The following is a description of a gene set: Genes down-regulated in HEK-293 cells (fibroblast) upon knockdown of CTBP1 but not of SATB1 by RNAi. studied in species Homo sapiens Human Gene Set: PURBEY_TARGETS_OF_CTBP1_NOT_SATB1_DN from publication Purbey PK, Singh S, Notani D, Kumar PP, Limaye AS, Galande S (PMID 19103759) Special AT-rich binding protein 1 (SATB1) acts as a global regulator of gene expression by recruiting various corepressor or coactivator complexes, thereby establishing a unique chromatin structure at its genomic targets in a context-dependent manner. Although SATB1 acts predominantly as a repressor via recruitment of histone deacetylase 1 (HDAC1) complexes, the precise mechanism of global repression is not clear. Here we report that SATB1 and C-terminal binding protein 1 (CtBP1) form a repressor complex in vivo. The interaction occurs via the CtBP1 interaction consensus motif PVPLS within the PDZ-like domain of SATB1. The acetylation of SATB1 upon LiCl and ionomycin treatments disrupts its association with CtBP1, resulting in enhanced target gene expression. Chromatin immunoprecipitation analysis indicated that the occupancy of CtBP1 and HDAC1 is gradually decreased and the occupancy of PCAF is elevated at the SATB1 binding sites within the human interleukin-2 and mouse c-Myc promoters. Moreover, gene expression profiling studies using cells in which expression of SATB1 and CtBP1 was silenced indicated commonly targeted genes that may be coordinately repressed by the SATB1-CtBP1 complex. Collectively, these results provide a mechanistic insight into the role of SATB1-CtBP1 interaction in the repression and derepression of SATB1 target genes during Wnt signaling in T cells., and this is the list of marker genes: NID2, ATP5F1B, NEK9, WBP11, SLC39A7, CD69, EXOC2, NDRG4, ZCCHC17, HAPLN4, TCF3, DNAH9, WDR4, DENND11, TULP2, SAYSD1, FETUB, ARHGAP25, JHY, TNFSF13B, GOLGA4-AS1, GOLGA2, SNPH, KLHL2, ITM2B, NDC80, DERA, TRIM55, SH3BP5, COLEC12, HERC2, HNRNPA1P16, IFT88, HRG, IL18RAP, MRPL41, NGEF, SOX2, SPOP, TMLHE, S100A10, PPFIBP2, ADAMTS1, MMP1, BEST2, PRR4, DDX4, FYN, RNF139, SLAMF8, CDKN2AIPNL, PLS1, KRT32, TCAF1, PRPF31, TNFSF8, DOC2B, TUBA3C, CD226, STMN1, PPP1R13L, CYB5B, SAGE1, ACKR4, ADGRV1, TACO1, GTF2E1, TMEM106C, TMEM25, HS3ST3B1, SEC23IP, UBE2D4, ACP5, ACAT2, AKIRIN2, SEPHS1, CDKN2D, WSB1 (NCBI Gene Id 26118), TMEM165, IMPACT, TARBP2, LPCAT1, PPP1R3A, PRPF4, TRH, MPG, FBXO31, FBXO9, DSCC1, PZP, SOAT1, POM121L10P, BBC3, ARL8B, SNX9, PIGHP1, LHX1, CHRM5, SYT12, CALM3, PARP11, SIVA1 (NCBI Gene Id 89639), AP3S1, ETV5, DDX43, KPNA1, SUPT20H, NPC1, JAK3, KBTBD6, KRT71, TBCB, CPA5, HSD17B8, APBB1IP, BET1L, CYP3A4, ANKRD13C, TBX1, POLR2E, ALOX5, TXNDC17, ENPP2, ITGAE, PIK3CB, VRK2, PABPC5, HAPLN1, NENF, CABLES1, POLR3E, BAK1, KLF12, IFITM3, PPP1R2C, DCTN4, PAK2, LMO1, KPNA2, SP4, CEACAM5, GPATCH2L, CIAPIN1, WARS2, PIK3CD, CNTN3, ARID1A, MIR100HG, GDF11, MAP3K7, PPP1R1B, NEB, CCDC186, PDE8B, SESN3, ATXN7, PRR16, RMI1, CLK3, GNG5, GPR143, NRXN3 (NCBI Gene Id 9369), WDR76, VDR (vitamin D receptor), DOP1A, CPVL, KISS1, NUF2, CTTN, PSORS1C2, MAGEA10, CRIP2, DNAI1, VPREB3, SLCO3A1, DSTN, AKAP1, CUEDC2, PTP4A3, CHPT1, TMEM8B, TSPO, PTPN21, PCDH20, VAMP2, NUDT14, IER2, PCDH8, GBP3, MAGEA4, NAA25, ST13, IRX5, NR3C2, MMP17, PMAIP1, RCHY1, PDE8A, FUT6, ABCG2, DDX19B, ADRA2A, PDPN, TMC5, ITM2A, CAPG, NES, RDH10, PPP2R1A, PLCXD1, RAPGEF2, RRM2, RAI2, RNF14, AGR2, SDCBP2, ZNF814, RASD1, CYP7B1, FUT1, FKBP1B, SLC25A36, ASXL2, GHITM (growth hormone inducible transmembrane protein), NCAPH, AREL1, SP110, BNIP3L, THRB, TUBA3D, ENSG00000286190, VBP1, WBP4, TOB2, PMM1, SPANXA2, PLEC, MICU1, GUSB, ROBO4, NAP1L4P1, SLC10A2, MYL6B, TAC3 (tachykinin precursor 3), DDIT4, PTPRF, BID, ABHD4, SRP19, PPP1CC, SLC5A1, KLHL20, AP3B2, MYO15B, TSC22D1, AICDA, GABRA2, DYRK1A, INTS9, DYNC2I1, TNMD, GDF10, BTN3A3 (NCBI Gene Id 135583), LEMD3, WWTR1, ENSG00000258843, PYROXD1, TMEFF1, SMARCD1, PPP3CA, ARHGEF12, GPR161, DDX20, RYR1, HS6ST1, AKNA, PHIP, NAALAD2, MAGEA6, MB, CTDSPL, MT3, DOCK4, TNFRSF25, C18orf32, GTSE1, DKK3, CKMT1A, PRDX1, DLK1, CXCR5, PAX9, TESK2, RORA, TIMM17B, GRM2, LINC00588 (long intergenic non-protein coding RNA 588), FGF5, GHR, CDCA7, SHB, TLE3, SNAPC5 (NCBI Gene Id 10302), ZFAND2B, PRRX1, F8A1, SAT1, KRT4, ZNF26 (zinc finger protein 26), HBS1L, PDE1A, SCN9A, PROS1, HNF1B, PI3, PRPF18, APLN, SERPINH1, MLPH, EPYC, OCA2, BLOC1S2, OGFOD2, MRPS16, HSP90B1, COQ3, RHOXF2B, RBM6, KIF14, ZNF236, KCNC4, OGT, ZNF436-AS1, GTF2H2C, FHIT, RAB5IF, MAPRE3, ZFY, FGA (NCBI Gene Id 2243), EIF5B, CLIP3 (CAP-Gly domain containing linker protein 3), RPL11, LONP2, ZCCHC2, CHST7, MARK3, ABCB8, TG, VSTM2L, GRB14, DISP1, KCNK1 (NCBI Gene Id 3775), GDE1, ARHGEF34P, GGCX, FBXW10, MDM4, SLIT1, TMEFF2, KLC2, PTPN22, ACSL5 (acyl-CoA synthetase long chain family member 5), ADTRP, MAPK1, FDXR, ZPBP, SNX5, TECPR2, DIP2A, ETS2, LCK, MALSU1, MARCHF1, PBX3, KLF2, HOXC6, C14orf119, UBL5, DZIP1, IFITM2, RCE1, ACOT13, CIB1, PRL, MEN1, CAD, HSF2, CRYBA1 (NCBI Gene Id 8146), PHOX2B (paired like homeobox 2B), ECEL1, PLK2, CRIPT, IGHG1, UBE4B (ubiquitination factor E4B), HDHD5, BIK, ATE1, VPS33B, NME5, CD55, MAGEB3, LINC00852, RNASE2